The following is a description of a gene set: The chemical reactions and pathways involving cysteine, 2-amino-3-mercaptopropanoic acid. Human Gene Set: GOBP_CYSTEINE_METABOLIC_PROCESS studied in species Homo sapiens, and this is the list of marker genes: CDO1, GCLM, GCLC, MPST (mercaptopyruvate sulfurtransferase), AGXT, CBS, CTH, MTHFD1, GGT1, CSAD, SLC7A11, ENSG00000274276